The following is a description of a gene set: from publication Bedogni F, Hevner RF (PMID 34321999) Mouse Gene Set: HEVNER_CORTEX_APICAL_AND_BASAL_INTERMEDIATE_PROGENITOR_CELLS Genes selectively expressed by intermediate progenitor cells (apical and basal subtypes) in embryonic day 14.5 mouse cortex. species: Mus musculus, and this is the list of marker genes: Ankrd6, Baz2b, Ccdc136, Ash1l, Sema5a, Psme4, Bcor (NCBI Gene Id 76075), Celsr1, Hmgn3, Rasgef1b, Rybp, Msi2, Kdm4c, Lrp8, Ints13, Sorl1, Coro1c, Ltbp3, Abcd2 (ATP-binding cassette, sub-family D member 2), Afap1, Plcxd2, Nckap5, Lsm5, Celf1, Ago1, Kat6b, Igsf8, Inhbb, Slc15a2, Golim4, Nt5dc2, Eomes, Sncaip, Rbm8a, Ptprk, Cbfa2t2, Hdac9, Chrna3, Vangl2, Numa1, Akna, Mfng, Pgm2l1 (NCBI Gene Id 70974), Sdc3, Btg2, Rcor2, Neurod4, Mfap2, Mib1, Insm1, Kif21a, Kat2a, Hey1, Frmd4a, Baz2a